The following is a description of a gene set: studied in species Homo sapiens The directed movement of iron ions from outside of a cell into the cytoplasmic compartment. This may occur via transport across the plasma membrane or via endocytosis. Human Gene Set: GOBP_IRON_IMPORT_INTO_CELL, and this is the list of marker genes: SLC39A8, ISCU, IFNG, LCN2, STEAP2 (STEAP2 metalloreductase), SLC11A2, TFR2, MIR210, CYBRD1, SLC39A14, STEAP4